The following is a description of a gene set: species: Homo sapiens Human Gene Set: chr16q22, and this is the list of marker genes: DDX28, SMG1P7, TERF2, DDX19B, DDX19A, DUS2, PDPR (pyruvate dehydrogenase phosphatase regulatory subunit), ESRP2, RN7SL543P, MATCAP1, ZNF23, NFAT5, RNU6-23P, NAE1, CDH16, DPEP2, RPL35AP33, TXNL4B, RNU4-30P, ZFHX3, UTP4, DPEP2NB, CTCF, CMTM3, CES4A, MIR328, RNU6-1061P, ENSG00000309842, VAC14-AS1, PDXDC2P-NPIPB14P, RNU7-90P, CLEC18C, EDC4, ATXN1L, CMTR2, AGRP, NOB1, VAC14, MIR140, KRT18P18, RPS2P45, CBFB (core-binding factor subunit beta), SNORA62, LCAT, ENSG00000299063, RANBP10, CALB2, CMTM4, HSF4, RPSAP56, CIAO2B, RNU6-1262P, TANGO6, ATP6V0D1, NOL3, TSNAXIP1, ENSG00000252040 (novel transcript), RNU1-123P, RNU7-71P, NQO1-DT, AARS1, TAT, SLC12A4, RPS27P26, RPS12P27, CTCF-DT, ZFHX3-AS1, EXOC3L1, SNORD111, CES3, CDH1, PDP2, MTSS2, CHST4, LRRC36, FTLP14, NIP7, MIR6773, TPPP3, NQO1, ZNF19, HCCAT5, RNU6-898P, RN7SL279P, CHTF8, CTRL, RNU6-22P, SLC9A5, RRAD, DDX19A-DT, RN7SKP118, RNU4-36P, DHODH, PLA2G15, CARMIL2, CDH3-AS1, ACD, CA7, ELMO3, SMPD3, TMEM208, PLEKHG4, KARS1P3, PHLPP2, CLEC18A, MIR1972-2, SNORD111B, HSD11B2, B3GNT9, CYB5B, MIR1538, HSPE1P5, SNTB2, GFOD2, PDF, PKD1L3, RPL39P31, FBXL9P, CES2, ENSG00000295751, SLC7A6OS, ATP6V0D1-DT, ATP5F1AP3, NUTF2, C16orf86, ENSG00000260520, ENKD1, TRADD, RNU6-208P, SF3B3, DHX38, HP (NCBI Gene Id 3240), RNA5SP429, DERPC, LOHAN2, ZFP90 (ZFP90 zinc finger protein), ENSG00000261260, TERB1, SLC7A6, LINC01572, SNORA70D, COG8, LINC02136, HYDIN, HAS3, E2F4, VPS4A, CENPT, ST3GAL2, ZNF821, PARD6A, SNORD71, ZDHHC1, PRMT7, PMFBP1, TMED6, NRN1L, AP1G1, NPIPB14P, EXOSC6 (exosome component 6), TAT-AS1, CDH3, THAP11, FCSK, KCTD19, PSKH1, IL34, TLE7, RNU6ATAC25P, ENSG00000212445, DYNC1LI2, MARVELD3, PSMB10, COG4, RNU6-359P, PDXDC2P, RIPOR1, NFATC3, PHAF1, ENSG00000305477, FBXL8, WWP2 (NCBI Gene Id 116013), FHOD1, DPEP3, IST1, DYNC1LI2-DT, ENSG00000302421, HPR